The following is a description of a gene set: studied in species Homo sapiens ECM and collagens. Human Gene Set: MODULE_47, and this is the list of marker genes: THBS1, CNN2, KCNK2, THBS2, MXRA5, SERPINE1, COLEC12, IGFBP7, POSTN, THY1, PLPP2, LRRC32, VAV3, TIMP3, ST7L, SCG5, FN1 (fibronectin 1), SPARC, COPE (COPI coat complex subunit epsilon), PLAGL1, F2R, EML1, FRZB, COL12A1, IGFLR1, DDR2, S1PR1, KDELR3, PKIB, MAP1B, PECAM1, MYLK, ISLR, LRP1, SV2B, ACTN1, PSG5, PAMR1, MEG3, MOXD1, NDUFAF3, COL1A2, VWF (von Willebrand factor), ACTG2, TEK, GJB2, ZNF521, CAVIN1, TGFBI, TNC, CALD1, AKR1C1, TNFAIP6, ADAMTS1, EHF, LOX, FGF12, DPYSL3, SGCE, RAB31 (RAB31, member RAS oncogene family), LOXL1, LTBP1, BGN, ALPK2, PALLD, PMP22, CD34, RGS16, COL4A2, JUN, BMP1, PMEPA1, LOXL2, EMP3, MRC2, GAS1, FYTTD1, SRGN, FLII, GSDME, GNG11, SCG2, PLAUR, TNFRSF11B, MCAM, CKAP4 (cytoskeleton associated protein 4), NRN1, CLIP3 (CAP-Gly domain containing linker protein 3), PHLDB1, PRR16, IGFBP4, SMTN, TAGLN, PTN, COL6A3, NAA11, MYL9, CRYAB, MMP2, ITGB5, ID3, TCF4, CTSK, FBLN1, APOA1, PTGIS, COL16A1, LAMB1, P4HA1, CDH5, CD99, HSD17B6 (hydroxysteroid 17-beta dehydrogenase 6), H19, LGALS1 (NCBI Gene Id 3956), ACTA2, ADAM9, WDTC1 (WD and tetratricopeptide repeats 1), DKK3, CLEC3B, FBLN2, PLOD1, PDGFRB, PLTP, COL3A1, SERPINH1, JAM3, IGFBP3 (NCBI Gene Id 3486), VIM, NOTCH3, DMRT2, HTRA1, SERPINF1, THSD7A, GJA1, MLLT11, LMCD1, CRISPLD2, ENPEP, CXCL12, LDB2, CXCR4, PCOLCE, FILIP1L, MFAP2, PRELP, TENM2 (teneurin transmembrane protein 2), PFKFB3, SPANXA1, CFHR1, RPS6KC1, FGFR1, COL6A1, COL1A1, SPON1, RGS5, LUM, C1S, ALDH1A3, CTSE, CCN2, COL15A1, HNMT, VGLL4, BAALC, GAS6, PLXND1, SIRT3, CNN1, VCAN, COL4A1, C1R, DAB2, CYP1B1, G0S2, DES, FPR1, COL18A1, CDH11, PDGFRL, ELOA, BST1, INHBA (NCBI Gene Id 3624), PPIC, WWTR1 (WW domain containing transcription regulator 1), RARRES2, SELENOP, FBN1 (NCBI Gene Id 7470, fibrillin 1), TMEM47, NNMT (nicotinamide N-methyltransferase), PDPN, TPM1, FZD7, MMD, PDGFRA, TM7SF3, HIF1A, EGLN3, SPOCK1, IL6, SEMA3C, DENND4B, AEBP1, FAP, PLAU, COL6A2, CNN3, ADNP, BASP1, SERPING1, MMP11, ZEB1, HOXA5, NBL1, LTBP2, CDKN1A, MARCKS, MAF, TIE1, CALU, AQP1, ECM1, SH3BP4, SLIT2, COL5A2, EDNRA